Given this list of marker genes ENG, F5, SHARPIN, TTC7A (NCBI Gene Id 57217), SMAD4, IL10RA, BMPR1A, ACVRL1, ARPC5, TAOK1, AMACR, IFIH1 (NCBI Gene Id 64135), ARPC1B, APC, GREM1, PTEN, CYP7B1, WIPF1, HPS1 (HPS1 biogenesis of lysosomal organelles complex 3 subunit 1), PLVAP, RBCK1, WAS, here is a description of the gene set: Hematochezia The passage of fresh (red) blood per anus, usually in or with stools. Most rectal bleeding comes from the colon, rectum, or anus. studied in species Homo sapiens Human Gene Set: HP_HEMATOCHEZIA